Given this list of marker genes KCTD7, UTP18, RRP12, NSMAF, NSD2, RNF4, HCFC1, SEPTIN2, ANXA2, HSP90B1, FBP1, FKBP2, S100P, CES1, RRAGD, BCAP31, NPC1, SRSF3, SPAG5, P4HB, NQO1, VCP, RNASE6, BSG, NUDT1, ASMTL, LYZ, TMEM41B, EIF4G1, ADCY9, FICD, SEC61B, YBX1, VDAC3, KDELR2, ADRM1, PSMC3, ENTPD6, MTSS1, PPARG, RALGDS, ZNF101, FCER1A, STX5, SLC39A7, FAH, CREB3L2, CNOT3 (CCR4-NOT transcription complex subunit 3), C1orf216 (chromosome 1 open reading frame 216), TIMM17A, ERF, MYDGF, GIPR, RAN, CKS2, DEGS1, UAP1, S100A4, CTSD, ELOB, DDX10 (DEAD-box helicase 10), PCSK5, PDIA6, STK10, RPN1, GNPDA1, HNRNPU, FOSL1, PLEKHM1, GCLM, ATP6V0D1, TSPO (translocator protein), GABPA, MOAP1, GCLC, SEC13, JUN, PTS, MCFD2, EMP1, TFPI, RNASE2, PSMD8 (proteasome 26S subunit, non-ATPase 8), GFPT1, GPNMB, CD63, TPST2, LILRB4, CD302, FNDC3A, JMJD6, CAPZB, HMOX1, PSMD11, UQCR11, ITGA5, GUK1, ZNF516, YWHAQ, HDDC2, PITPNB, LAMP1, RBBP4, PITPNA, ITGB7, HOMER3, U2AF1, HEXA, SEC63, PDIA3, SEC24D, KEAP1, HSPA5, FAM20B, DNM2, TCF25, GRN, GOLGA2 (NCBI Gene Id 2801), TRAPPC3, CYBA, POR, ALOX5AP, BLVRB, IBTK, UBE2H, CTSL, NHP2, SEC31A, DRAP1, AOAH, TBC1D1, PSMD7, MAPKAP1, BLOC1S1, TLK1, KLC1, ATG4B, MSR1, IL1R2, GMFG, GSTP1, SLC36A1, ATXN2L, LRRC42, PDIA4, NUCB1, MAPRE1 (microtubule associated protein RP/EB family member 1), ALDOA, UFD1, SEC23A, ETF1, PGM3, HLA-DMB, RBM42, GSR, ATP6V0C, MRPL23, NDUFB7, EWSR1, HTATIP2, RABAC1, PTOV1, TXLNA, PPIF, HRAS, RRBP1, NDUFA1, GTPBP6, TBC1D9B, TESK1, CD163, TMED9, TMED5, CAPNS1, HYOU1, TRIM16, PHF1, KXD1, SNAPC1, LHFPL2, EMC2, TSPYL2, ALAS1, SLC16A6, IL16, POFUT2, IRAK1, PLIN2, SQSTM1, OSBP, NOTCH3, AFG3L2, LMNA, FCN1 (ficolin 1), ITGB2, RUSC2, CALU (calumenin), PPIB, PIR, DVL3, here is a description of the gene set: Adoptive T-cell Therapy (ACT) involves using tumor-infiltrating lymphocytes (TIL) isolated from metastatic melanoma and expanding them ex vivo prior to infusion into lympho-depleted patients. This is one of the most promising approaches to treat metastatic melanoma, with the rates of clinical response between 48-50% based on studies done at NCI, M.D. Anderson Cancer Center (Houston, TX), and Sheba Medical Center (Tel Aviv, Israel). In the Phase II ACT Trial at M.D. Anderson Cancer Center, our group has uncovered an association between positive clinical response and the amount of CD8+ tumor-infiltrating lymphocytes expressing B and T Lymphocyte Attenuator (BTLA), a reported inhibitory receptor on T-cells. We used microarrays to detail the differences in the global programme of gene expression between CD8+BTLA+ vs CD8+BTLA- TILs in order to understand the molecular basis of the clinical association. Human Gene Set: GSE43260_BTLA_POS_VS_NEG_INTRATUMORAL_CD8_TCELL_UP from publication Haymaker CL, Wu RC, Ritthipichai K, Bernatchez C, Forget MA, Chen JQ, Liu H, Wang E, Marincola F, Hwu P, Radvanyi LG (PMID 26405566) species: Homo sapiens Genes up-regulated in tumor-infiltrating CD8 T cells: BTLA+ versus BTLA-.